The following is a description of a gene set: species: Homo sapiens from publication Fu W, Ergun A, Lu T, Hill JA, Haxhinasto S, Fassett MS, Gazit R, Adoro S, Glimcher L, Chan S, Kastner P, Rossi D, Collins JJ, Mathis D, Benoist C (PMID 22961053) Human Gene Set: GSE40274_FOXP3_VS_FOXP3_AND_XBP1_TRANSDUCED_ACTIVATED_CD4_TCELL_DN Genes down-regulated in CD4 T conv over-expressing: FOXP3 versus XBP1 and FOXP3. The transcription factor FoxP3 partakes dominantly in the specification and function of FoxP3+ CD4+ T regulatory cells (Tregs), but is neither strictly necessary nor sufficient to determine the characteristic Treg transcriptional signature. Computational network inference and experimental testing assessed the contribution of several other transcription factors (TFs). Enforced expression of Helios or Xbp1 elicited specific signatures, but Eos, Irf4, Satb1, Lef1 and Gata1 elicited exactly the same outcome, synergizing with FoxP3 to activate most of the Treg signature, including key TFs, and enhancing FoxP3 occupancy at its genomic targets. Conversely, the Treg signature was robust to inactivation of any single cofactor. A redundant genetic switch thus locks-in the Treg phenotype, a model which accounts for several aspects of Treg physiology, differentiation and stability., and this is the list of marker genes: JAML, UBL7 (ubiquitin like 7), FBXO31, CEP95, IL21R, TNFSF4, PDSS1, EGR1, STK4, SMAD4, TANGO2, SHARPIN, CD3G, WDR12 (WD repeat domain 12), PDHB, RCBTB2, COQ2, MPRIP, TMC6, NABP1, SLC49A4, NELFA, AKAP13, DDHD1, PITPNM2, ALS2CL, SLAMF6, ITGAM, AFF3, BTLA, SLC43A1, SLC50A1, ST6GAL1, BMP2K, NAF1, SDR42E1, RANBP10, TOX, CD5, CD55, MPP1, ZCCHC2, APOBEC2, CAMK1D, TSPAN2, AMIGO3, SEMA7A, CTSZ, RNF213, EIF4G3, LEF1, TTC13, RBM38, SEMA4B, ZBTB32, AMZ2, C15orf39, TMPRSS12 (transmembrane serine protease 12), SRRM1, TBXA2R, ARL5C, SNAI3, KIN, TGFBR1 (NCBI Gene Id 7046), PNPT1, ALCAM, LTK, ACTN1, MCOLN2, SMYD1, MIER1, PRDM4, PPRC1, SURF2, INPP1, TIAL1, TTBK2, SLC6A19, IL6R, NRAS, ACAP3, SLC30A4 (NCBI Gene Id 7782), LYPD6B, CNOT6L (NCBI Gene Id 91275), RCSD1, FAM3C, LYST, ITIH2, PLS1, MAPK11, MIR17, SETD7, PTEN, IZUMO1R, MRI1, ADI1, PHLPP1, IFNGR1, RAPGEF5, SLC15A2, HSDL1, NGLY1, EGLN3, LRBA, TMEM219, FAS (NCBI Gene Id 355), THEMIS, CD86, ITPR2, TAPT1, SLC37A3, EHD4, GPR183, UVRAG, FSTL5, MAP3K5, KAT2B, RASGRF2, OSM, MCTP2, FAAH, ARL6IP4, MYB, CXCR5, SMC4, DUSP4, MYLIP, THEMIS2, HBS1L, TTYH3, RAB9A, ATP1B1, MYH3, ABLIM1, TECPR1, IDH2, RDH5, CCS, TCF7, NPRL3, VPS13C, ZBTB7B, PLEKHG2, NDUFAF4, LPAR6, MAP4K2, MIR188, IFT80, PDK1, KCTD13, CTLA4, GOLM2, DTX3, ID3, TFB2M, P2RX4, PARP14, IPPK